The following is a description of a gene set: Mouse genes annotated to increased melanoma incidence (MP:0010275) retrieved from the Mouse Genome Informatics database via MouseMine Mouse Gene Set: MP_INCREASED_MELANOMA_INCIDENCE species: Mus musculus from publication Motenko H, Neuhauser SB, O'Keefe M, Richardson JE (PMID 26092688), and this is the list of marker genes: Hgf, Kras, Braf, Cdkn2a, Nras